Given this list of marker genes Camk2a, Camk2b, Camk2g, Camk2d, Camk1g, here is a description of the gene set: studied in species Mus musculus Mouse Gene Set: GOCC_CALCIUM_AND_CALMODULIN_DEPENDENT_PROTEIN_KINASE_COMPLEX An enzyme complex which in eukaryotes is composed of four different chains: alpha, beta, gamma, and delta. The different isoforms assemble into homo- or heteromultimeric holoenzymes composed of 8 to 12 subunits. Catalyzes the phosphorylation of proteins to O-phosphoproteins.